Given this list of marker genes NARF, ECM1, MDH1, RETREG1, SLIRP, TNFAIP8, TFF3, OGFOD2 (NCBI Gene Id 79676), STAU2, FAF2, TRIM33, CD4, IGF2, NCOR1, PPP6R3, FN1, PYY, ITGB5, XPNPEP1, HAO1, SEC62, OLA1, COL6A1, RPS6, CRABP2, PLAA, DDX5, SEL1L, TMEM165, TNPO1, USP3, SDHA, IL6ST, SIX3, TRMT1L, PPP3CA, USP9X, UBR5, TRIM29, ELMO2, C6orf62 (chromosome 6 open reading frame 62), CALCOCO1, DPYSL2, GBP2, KIF5B, TXNIP, HNRNPH1 (heterogeneous nuclear ribonucleoprotein H1), USP7, ENPP2, CCDC47, TMX1, TIMP2, here is a description of the gene set: studied in species Homo sapiens BACKGROUND: Deregulation of the Wnt/ beta-catenin signal transduction pathway has been implicated in the pathogenesis of tumours in the mammary gland, colon and other tissues. Mutations in components of this pathway result in beta-catenin stabilization and accumulation, and the aberrant modulation of beta-catenin/TCF target genes. Such alterations in the cellular transcriptional profile are believed to underlie the pathogenesis of these cancers. We have sought to identify novel target genes of this pathway in mouse mammary epithelial cells. METHODS: Gene expression microarray analysis of mouse mammary epithelial cells inducibly expressing a constitutively active mutant of beta-catenin was used to identify target genes of this pathway. RESULTS: The differential expression in response to DeltaNbeta-catenin for five putative target genes, Autotaxin, Extracellular Matrix Protein 1 (Ecm1), CD14, Hypoxia-inducible gene 2 (Hig2) and Receptor Activity Modifying Protein 3 (RAMP3), was independently validated by northern blotting. Each of these genes encodes either a receptor or a secreted protein, modulation of which may underlie the interactions between Wnt/beta-catenin tumour cells and between the tumour and its microenvironment. One of these genes, Hig2, previously shown to be induced by both hypoxia and glucose deprivation in human cervical carcinoma cells, was strongly repressed upon DeltaNbeta-catenin induction. The predicted N-terminus of Hig2 contains a putative signal peptide suggesting it might be secreted. Consistent with this, a Hig2-EGFP fusion protein was able to enter the secretory pathway and was detected in conditioned medium. Mutation of critical residues in the putative signal sequence abolished its secretion. The expression of human HIG2 was examined in a panel of human tumours and was found to be significantly downregulated in kidney tumours compared to normal adjacent tissue. CONCLUSIONS: HIG2 represents a novel non-cell autonomous target of the Wnt pathway which is potentially involved in human cancer. Genes down-regulated in HC11 cells (mammary epithelium) by expression of constantly active CTNNB1. Human Gene Set: KENNY_CTNNB1_TARGETS_DN from publication Kenny PA, Enver T, Ashworth A (PMID 15642117)